Given this list of marker genes MT-ND6, MTND2P4, MTND4P12, MT-TE, MTND6P4, MTND1P36, MT-TH, MT-TL2, MTATP6P2, MTND2P16, MTND5P11 (NCBI Gene Id 100506169), ARHGAP15, MTND1P7, MTND1P15, MTCO1P45, MT-TS2, MTCO3P22, MTND2P38, MT-TP, MT-TT, SLC39A10, RPL18AP8, MT-CYB, MT-ND2, MTCO1P2, MTND4P24, MTCO3P13, MT-ND5, MTND4LP1, MTCYBP35, MTCO1P25, RNU6-656P (NCBI Gene Id 106479857), MTND2P33, MTND1P14, MT-TI, MTND2P24, MT-TF, MTND4LP19 (NCBI Gene Id 107075241, MT-ND4L pseudogene 19), MTND1P30, MTND1P6, MTND1P22, MTCO3P12, MTND1P9, NMTRS-TGA3-1, MTND5P10, MTND1P37, MT-TM, MTATP6P3, MT-RNR1, MTND3P19, MTND1P11, MTCO1P12, MTCYBP18, MTND2P8, here is a description of the gene set: from publication Yevshin I, Sharipov R, Kolmykov S, Kondrakhin Y, Kolpakov F (PMID 30445619) Genes containing one or more binding sites for (TFAM) in their promoter regions (TSS -1000,+100 bp) as identified by GTRD version 20.06 ChIP-seq harmonization. species: Homo sapiens Human Gene Set: TFAM_TARGET_GENES